The following is a description of a gene set: Reactome Pathway: Defective SLC33A1 causes spastic paraplegia 42 (SPG42) species: Homo sapiens part of: SLC transporter disorders The human gene SLC33A1 encodes acetyl-CoA transporter AT1. SLC33A1 transports cytosolic acetyl-CoA (Ac-CoA) to the Golgi apparatus lumen, where it serves as the substrate for acetyltransferases that O-acetylates sialyl residues of gangliosides and glycoproteins. Defects in SLC33A1 are the cause of spastic paraplegia autosomal dominant type 42 (SPG42; MIM:612539), a neurodegenerative disorder characterised by a variable speed of (but progressive) weakness and spasticity of the lower limbs. Defects in SLC33A1 can also cause congenital cataracts, hearing loss, and neurodegeneration (CCHLND; MIM:614482), an autosomal recessive disorder characterised by congenital cataracts, severe psychomotor retardation, and hearing loss, together with decreased serum ceruloplasmin and copper., and this is the list of marker genes: SLC33A1